The following is a description of a gene set: species: Homo sapiens A dynamic process of chromatin reorganization resulting in changes to chromatin structure. These changes allow DNA metabolic processes such as transcriptional regulation, DNA recombination, DNA repair, and DNA replication. Human Gene Set: GOBP_CHROMATIN_REMODELING, and this is the list of marker genes: TRIM28 (NCBI Gene Id 96054), RNF8, HDGF, KDM5A, RLF (RLF zinc finger), CHAF1B, CABIN1, ARID1B, HAT1, CDY1, TRRAP, NPM3, HDAC9, H2BC11, KAT6B, USP51, HMGA1, PHF19, EZHIP, SLFN11, DDX4 (NCBI Gene Id 54514), NPM1 (NCBI Gene Id 4869), NFKBIZ, UBN1 (ubinuclein 1), ZNFX1, H1-2, TTF1, CTCFL, METTL3, PER2, RSBN1, PCGF6, PRMT8 (NCBI Gene Id 56341), NSD3, HNRNPU, VPS72, TAF1, EGR1, TSPY8, GATA3, MBD3L3, ZBTB7A, HIPK2, MACROH2A1, TDRD1, SMARCA4, ACTR8, SFPQ, ATAD2B, BCOR, CENPI, MYD88, KMT2D, TDG, TUT4, PHF2, MYOCD, TPR, CENPP, ARID2, H2AC18, SIRT1, SHPRH, NAA50, MOV10L1, TDRD12, TRIM27, TSPYL1, CHD1L, APP, HIRA, TRIP12, PAK1, BRCC3, CDYL, ATF2, APOBEC3C, CDKN2B-AS1, BAZ1B, NIPBL, NTMT1, RRP8, H1-6, H3C1, RBBP4, H2AC19, HNRNPK, LMNA, SPOCD1, DEK, YY1 (YY1 transcription factor), DNAJC9, H4C4, SETD2, KAT8, CHAF1A, MIS18A, PRDM9, ZNF274, DPF3, BARD1, MORC1, USP36, PWWP2B, H2BC21, UBR2, ALKBH1, BAP1 (BRCA1 associated deubiquitinase 1), APEX1, SUV39H1, TDRD5, SETDB2, XIST (NCBI Gene Id 7503), TEX15, PRMT2, PADI2, CHD3, HDAC3, NSD1, ALKBH4, EZH1 (enhancer of zeste 1 polycomb repressive complex 2 subunit), MTF2 (NCBI Gene Id 22823), BABAM1, H4C2, H4C9, DTX3L, DAXX, FBLL1, TSPYL6, H2AC15, EPOP, H2AZ2, SMARCAD1, ANP32B, RB1, KDM6B, SPTY2D1, KDM3B, H3-3B, TRMT112, APLF, PCID2, NAP1L2, TSPY3, ARB2BP (NCBI Gene Id 131909), ACTR5 (NCBI Gene Id 93972), CBX3, SUV39H2, PIWIL1, CBX5, H2BC7, PHC1, MTA2 (metastasis associated 1 family member 2), BRD1, N6AMT1, H4C5, SETD4, TSPYL4, PHF1, C6orf89, MPHOSPH8, BCL7B, TAF9, ATM, DDX21, ATF7IP, KDM1A, PKN1, CTCF, LHX2, METTL23 (methyltransferase 23, arginine), WT1, POLE3, KMT5A, PML (PML nuclear body scaffold), GLMN, RERE, GATAD1, ING4, SF3B1, RIOX1, VRK1, MIR29C, APOBEC3A, CLOCK, SETBP1, CTR9, TADA2B, MECP2, USP15, SETMAR, PRKCA, EHMT1, MAEL, HDGFL1, SETSIP, ZNF335, SAMD1, ZNF93, H4C3, H2AC12, EYA1, ZMPSTE24, PRDM7, NAP1L4, CHEK1, TSPY4 (NCBI Gene Id 728395), H3C8, INO80B, GTF2B, USP21, SMARCD3, NAP1L3, HDAC10, H2BC4 (H2B clustered histone 4), RSF1, CHD5, H1-3, BCL6, PRKAA1, EED (embryonic ectoderm development), H4C16, SETD1A, MECOM, KDM6A, NSD2, CHD1, H3C10, TSPY2, TASOR, SETD1B, H2AC1, MTA3, KDM4D, UIMC1, MBD3L4, TSPYL2, PHF10, KDM5B, KDM4E, H2AC21, TFAP2C, H2AC6, AICDA, HELLS, NFAT5, PRMT7, TNP1, L3MBTL1, PCGF2, H1-1, PRDM6, TP53, HNRNPC, ASF1B, KAT2A, NFE2, PADI6, NDN, H3C11, MIER1, PRKCB, KMT2C, KDM5C, MBD1, FOXP3, EOMES, CENPV, SUPT16H, ERCC6, CBX1, SMARCE1, SPEN, H2AP, NUDT5, GTF3C4, KAT2B, NFRKB, HDAC4, BICRAL, RNF20, HDGFL2, ZFP92, MOV10, HP1BP3, H3-4, DPF1, TADA2A, SMARCC2, RBM14, L3MBTL3 (NCBI Gene Id 84456), NR5A2, LMNB2 (lamin B2), PAX6, HDAC7 (NCBI Gene Id 51564), CHRAC1, TLE6, ZBTB1, NAP1L1, H2AC8, H2AC25, MSL1, MORC2, MYC, APOBEC3H, APOBEC2, AURKA, HDAC2, NCOA3, PAX7, H4C15, MEAF6, MYSM1, H2BC1, SPIN1, NOC2L, APOBEC3G, PHF8, H2AB3, SDR16C5, CENPA (centromere protein A), H2BC13, ESR1, EHMT2, USP22, UBE2A, PARTICL (NCBI Gene Id 100630918, promoter of MAT2A antisense radiation-induced circulating long non-coding RNA), PAXIP1, ARB2A, TUT7, H4C8, PER1, CENPW, DIRAS3, BMI1 (NCBI Gene Id 648), CHD7, INO80E, KMT5C (lysine methyltransferase 5C), SS18, BAHD1, EPC1, NRDE2, TSPY9, ASIP, PRIMPOL, APOBEC1, BEND3, FKBP6, RYBP, H1-8, BTBD18, TAF1L, PHB1, CFDP1, TET2, USP49, DPF2, HDAC8, H4C6, TASOR2, SMYD3, SUZ12, TSPYL5, PRDM16, PRMT3, H4C11, H2AC4, DCAF1, YTHDC1, BICRA, DPY30, HDAC5, DDX23, MBD3L2B, RUVBL1, TEX19, SCMH1, KDM7A, TSPY1, KMT5B, KDM2A, PCGF5, H2AX, H2AC16, H4C14, TGM2, KAT5, ATR, WBP2, WDR5, INO80C, EP300, COPRS, DPPA3, SGF29, SETDB1, RNF168, ACTR6, UBR5, ZNF91, LRIF1, GLYR1, BRD2, PCGF3, RBM15 (RNA binding motif protein 15), ZNF304, H3C13, MSL2, ATRX, GPX1, STPG4, FAM47E (NCBI Gene Id 100129583), PARP2, UHRF2, NAP1L6P, KDM8, ARID1A, ARID4B, MBD3L5, JADE1, AXIN1, DNMT3L, PIWIL2, INO80, DCAF13, SETD5, SATB2, FOXA1, JMJD6, JADE2, H2BC6, SIRT6, EYA2, ASZ1, JMJD1C, MBD3L2, SMYD2 (SET and MYND domain containing 2), PRKAA2, H2AC20, INO80D, ACTL6B, MYCN, SUDS3, BRD7, ATAD2, H2AC13, CHD4, UCHL5, NAA60, EYA3, H2AJ, CREBZF, HPF1 (histone PARylation factor 1), HCFC2, CDK9, HDAC6, NAA40, LIN54, HUWE1, TET3, CDY2A, H4C13, PRMT5, PRMT9, SRCAP, MBD3, CIZ1, IGF2, KDM4A, ASF1A, SATB1, H1-5, TP63, EZH2 (enhancer of zeste 2 polycomb repressive complex 2 subunit), ARID4A, SMARCA2, H3C7, METTL4, KDM4C, CHTOP, KMT2B, RIF1, H3-3A (NCBI Gene Id 3020), CDKN1C, SMARCD2, H3C15, HMGB2, RBBP7, MTA1, H2AC7, BAZ2B, TFPT (NCBI Gene Id 29844), TAF10, SUPT6H, GSK3A, BRCA2, MACROH2A2, PRDM2, BAZ2A, MEN1, SMARCB1, H1-4, PADI4, H1-10, PCGF1, RING1, KDM1B (NCBI Gene Id 254751), LBR, HASPIN, BPTF, SMYD5, MBD3L1, NPM2, TDRD9, HMGB1, H3C2, RAD50, JDP2, ITGB3BP, RPS6KA5, MBD2, KDM5D, SSRP1, BRDT, CDK1, TRIM37, H2BC14, PIK3CA, PSIP1, BRD3, BUB1, BRPF3, BRD9, ING2, H3C3, MYBBP1A, PRDM8, CREBBP, CHD8, H4C12 (NCBI Gene Id 8362), H1-9P, SMCHD1, RNF2, PRKDC, H2AC17, CGGBP1, MRE11, HCFC1, WAC, MAP3K7, SUPT5H, SMARCD1, UTY (NCBI Gene Id 7404), SIRT2, KAT6A, CECR2, SRPK2, NCOA1, MCM3AP, SETD3, H3C4, PTENP1-AS, SIN3A, KDM4F, DOT1L, JAK2 (Janus kinase 2), H2BC17, KAT7, SAMD7 (sterile alpha motif domain containing 7), KLF2, PKM, KDM4B, GRWD1, PBRM1, USP7, KAT14 (NCBI Gene Id 96680), FBL, HDAC1, SET, REST, H3C6, ZDBF2, LMNB1, H2BC10, SMARCA5, ACTL6A, ACTB, APOBEC3B, NASP, CENPN, HIPK4, ASH1L, SART3, H2BC8, PPM1D, DDB1, DNMT3A, RLIM, H3C12, SOX9, GATAD2A, HR, RBBP5, MIR29B1, ING3, SPI1, RIOX2, NAP1L5, H2AB1, TOP1, SUPT4H1, FBXL19, H2BC15, USP16, HJURP, ZFP57, PIH1D1 (PIH1 domain containing 1), PRMT6, MIR182, OIP5, H2AB2, CDY1B, BAZ1A, TET1, KDM2B, PWWP2A, MIR29A, PIWIL4, BRCA1, H4C7, H2BC9, RAD54L2, SIRT7, MCM2, JARID2, SETD7, RPS6KA4, PRDM13, RUVBL2, IFI16, SKP1, H2AZ1, H1-0 (H1.0 linker histone), BRPF1, YEATS4, IRF4, GATAD2B, KPNA7, CDY2B, OGG1, SMYD1, CDK2, SMARCC1, KMT2E (NCBI Gene Id 84147), H2AL3, BRD4, UHRF1, IWS1, ZNF827, H2AC11, NBN, YEATS2, CHD6, PRMT1, DMAP1, RESF1, KDM3A, DYRK1A, ASH2L, DNMT1, KMT2A, PPHLN1, CARM1, H4C1, MCRS1, CHD2, USP3, ZNHIT1, APOBEC3F, C19orf84, ZNF445, PRDM14, HMGA2, TBR1, TSPY10, RBM15B, SPHK2, TAF6L, HDAC11, BCL7C, H3C14 (H3 clustered histone 14), SMARCA1, H2BC3, BCL7A, MYO1C